The following is a description of a gene set: Mouse Gene Set: GOMF_RECEPTOR_SERINE_THREONINE_KINASE_BINDING Binding to a receptor that possesses protein serine/threonine kinase activity. species: Mus musculus, and this is the list of marker genes: Neo1, Fkbp1a, Oprk1, Bmp6, Acvr1c, Bmp10, Cav1, Cfc1, Cripto, Scube3, Smurf1, Bmp3, Smad7, Src, Cdh5, Pebp1, Bmp7, Fadd, Pycard, Inhba, Magi2, Rspo2, Smad6, Bmp2, Nodal, Gpr17, Bmp4, Synj2bp (NCBI Gene Id 28115), Mdm2, Elapor2, Bmp5, Oprd1